Given this list of marker genes DNAAF5, TTC12, CFAP300, DNAAF1, DNAAF3, DNAH7, DNAAF11, CCDC39, ZMYND10, here is a description of the gene set: Absence of the inner dynein arms of respiratory motile cilia, which normally are situated within the peripheral microtubules of motile cilia. This feature is usually appreciated by electron microscopy. Absent inner dynein arms species: Homo sapiens Human Gene Set: HP_ABSENT_INNER_DYNEIN_ARMS